The following is a description of a gene set: The process whose specific outcome is the progression of a ganglion over time, from its formation to the mature structure. Mouse Gene Set: GOBP_GANGLION_DEVELOPMENT studied in species Mus musculus, and this is the list of marker genes: Sema3f, Nrp1, Sema3a, Nrp2, Cyp1b1, Phox2b, Pou4f2, Six4, Six1, Ctnnb1, Tulp3, Dicer1, Unc5c, Insm1, Tubb3, Ascl1, Fzd3